The following is a description of a gene set: Platelet Adhesion to exposed collagen Mouse Gene Set: REACTOME_PLATELET_ADHESION_TO_EXPOSED_COLLAGEN species: Mus musculus, and this is the list of marker genes: Lyn, Gp9, Col1a2, Fcer1g, Gp5, Fyn, Gp1ba, Col1a1, Gp6, Gp1bb, Adamts13, Vwf